Given this list of marker genes rpoB, rpoC, rpoZ, rpoA, here is a description of the gene set: Reactome Pathway: Antimicrobial action and antimicrobial resistance in Mtb Antimicrobial compounds kill microorganisms or inhibit their growth, either in the host, outside on the skin (antiseptics), or in the environment (disinfectants). In the host they are named after the target symbiont, for example antibiotics, antifungals, and antiparasitics. It suffices to permanently stop an essential pathway in the symbiont to kill it. Broad spectrum antimicrobials usually target a conserved pathway like protein synthesis or cell wall construction, in order to affect a whole taxonomic group (Arenz & Wilson 2016, Barry et al. 2007, Green 2002).<br><br>Resistance of microorganisms (bacteria, viruses, parasites) to antimicrobials is one of the most important public health problems. Many mechanisms exist, and they are either acquired by mutation, by horizontal gene transfer, or are already intrinsic to the organism. The main mechanisms are modification of the antimicrobial, or its removal from the place of action, modification of its binding partner in the affected pathway, or usage of a back-up pathway. Participation of the organism in a consortium (like in biofilms) enables additional resistance mechanisms (Aminov & Mackie 2007, Peterson & Kaur 2018, van Acker et al. 2014, van Acker & Coenye 2016).<br><br>The events described here are specific to Mtb infection. species: Homo sapiens part of: Infection with Mycobacterium tuberculosis